The following is a description of a gene set: Genes up-regulated in CD8 T cells: KLRB1 int versus KLRB1-. Human Gene Set: GSE33425_CD161_INT_VS_NEG_CD8_TCELL_UP from publication Walker LJ, Kang YH, Smith MO, Tharmalingham H, Ramamurthy N, Fleming VM, Sahgal N, Leslie A, Oo Y, Geremia A, Scriba TJ, Hanekom WA, Lauer GM, Lantz O, Adams DH, Powrie F, Barnes E, Klenerman P (PMID 22086415) species: Homo sapiens This SuperSeries is composed of the SubSeries listed below., and this is the list of marker genes: ARL5A, SERPINI1, NDFIP1, PLEKHB2, ALCAM, C6orf120, PHYH, CDK8, OSTF1 (NCBI Gene Id 26578), SKIC8, DHRS4, CD9, HIBADH, RECK, TNFRSF18, CIAPIN1, COX17, TNKS2, PPP3CB, CMAS, CYTH3, SDHA, AHNAK, EMB, EI24, TMEM30A, SKAP2, SNX6, ST8SIA1, NUDT4, TM7SF3, RGS2, C1orf43 (NCBI Gene Id 91192, chromosome 1 open reading frame 43), GLCE, SAR1B, DEGS1, RRAGC, FGL2, ASAH1, LSM14A, DUSP16, RNF149, SPAST, ARAP3, ITGA4, SRGN, TMEM147, EPS15, TM9SF2, B3GNT2, RNF11, BCL2A1, RAB8A, NUDT16L1, TNFSF11, KCTD12, RSU1, SMPDL3A (sphingomyelin phosphodiesterase acid like 3A), PSMB9, ARRB1, UBE2D3, MDFIC, PRKD3, IVNS1ABP, CAMLG, VPS4B, ATP6V1C1, GANAB, AKAP12, RNF7, CPD, ATF1, ARF4, PRP4K, PERP, ANTXR2, TRIM59, KLHDC2 (NCBI Gene Id 23588), HNRNPK, PLSCR1, ITIH5, PON2, HMGCS1, DAZAP2, ROCK1, GBE1, PTPN22, BRIX1, IFNGR1, RAB28, PPP2R5C, HLA-C, RAB24, DIDO1 (NCBI Gene Id 85362), CNIH1, SLC1A5, KLRD1, EPB41L2, TRAF5, CCL5, ANXA2, LIN7C (lin-7 homolog C, crumbs cell polarity complex component), PSEN2, TCF12, HAUS3, PTP4A2, HEXA, PTDSS1, SMU1, RCOR1, ITGAV, MFF, NAPSA, U2SURP, ADAM10, SMARCA2, VMP1, AFG2A, TNPO1, RNFT1, VAMP4, YWHAH, YTHDF3, OSBPL5, SQLE, BCAP31, DNAJC9, PGK1, SERINC3, S100A10, UBL3, PTER, SNX9, PRDX6, MFSD14A, ITM2B, USP19, NABP1, EEA1, ZFP36L1, RHOQ, IMMP1L, CA2, OSER1, TTC39B, ADH5, YIPF1, WRNIP1 (WRN helicase interacting protein 1), SNIP1, DOCK5, ARF6, BCL2L11, UBA3, SNX10, PLAC8 (NCBI Gene Id 95621), PLEKHA1, LAPTM4A, NAT1, PCBP1, CD82, MXI1, RAB2A, OTULINL, CTNNA1, COLGALT1, EID1, NRGN, MAGED2, CBX5, ATP6AP2, DNAJB9, ARL1, CD244, SEPTIN2, PPID, SAFB (NCBI Gene Id 6294), SMC3, SLTM, EED, MCEE, PRKCH, PPP1CB, CRLF3, PELI1, ERH, UNC119B, GTF2E2, TRNT1, PTPN13, RAB10, FASLG, ACSL4, SLMAP, RPL10, SMNDC1, NAA38, SC5D, GNG10, RNF5 (ring finger protein 5), IL7R